The following is a description of a gene set: Genes up-regulated in day 40 memory B cells versus day 40 germinal center B cells. Human Gene Set: GSE11961_MEMORY_BCELL_DAY40_VS_GERMINAL_CENTER_BCELL_DAY40_UP species: Homo sapiens To obtain insight into the genetic basis of the increase of functional activity of memory B cells over time, we compared the gene expression profiles of day 7 and day 40 NP-specific/IgG1 memory B cells, GC B cells and plasma cells in immunized WT mice and naïve B cells, before and after activation in vitro. from publication Kaji T, Ishige A, Hikida M, Taka J, Hijikata A, Kubo M, Nagashima T, Takahashi Y, Kurosaki T, Okada M, Ohara O, Rajewsky K, Takemori T (PMID 23027924), and this is the list of marker genes: TUT7, HAUS5, PLXNC1, FIBP (FGF1 intracellular binding protein), ARMC6, ROBO2 (NCBI Gene Id 90370), MFSD2B, VPS33B, AMMECR1, AQP9, RGS9, XPO5, FYCO1, WDFY2, LZTS2, HINT3 (histidine triad nucleotide binding protein 3), CHEK2, TBX3 (T-box transcription factor 3, NCBI Gene Id 91834), SEC14L2, ZKSCAN4, STARD3, ABCC3, CNIH4, ZNF420, VPS54, TMEM43, RAI2, NPB, FBXO4, GRIK1, CNTN3, COG4, PES1, IPO4, DTNB, APOOL, POGK, PDZK1IP1, TDRD12, TRAPPC12, SERAC1, KLC3, TRAPPC14, LSM10, GPSM2, GABRG1, PTPN12, KCNC2, TPCN2, MPDZ, EPHA5, ADH4, NAP1L3, ANKRD29, ZNF354A, C2CD2, ARHGEF39 (NCBI Gene Id 84904), FIGN, FAT3, RHOT2, PLSCR3, TBC1D32, DPY30, AP5Z1, ICAM2, ZBTB42, ZNF438, RNF40, WDR25, ARHGAP45, SOCS4, CNTNAP2, TBRG4, SLIT2, PPIL6, LAD1, OSBPL5, HSPA8, NOVA1, ANK2, DZANK1, USP21, PLEKHO2, MROH1, EFNA5, SMTN, LASP1, ANO10, RGS8, CFAP300, FARSA, DNAJA1, KNSTRN, ARHGAP5, PKP3, DUS3L, PYGB, FAM216A, IGDCC4, PLOD2, MYBPC1, TTC3, DEGS1, NGLY1, CDH1, TNKS1BP1, SRR, ZFPM1, ASS1, NOC4L, TSGA13, CXCL13, SERPINC1, EDN3, LTBP1, FAM89A, SLC39A12, ZSCAN29, PSRC1, OSBPL3, MECOM, SNRNP35, SPATS1, CCNA2, PLEKHH1 (NCBI Gene Id 57475), GNB2 (G protein subunit beta 2), TSGA10, GGCX, C1orf159, LZTR1, PLCB3, C1R, CCP110, POLR1B, CRADD, COX7B2, COL20A1, TPBG, BCAS1, KAT2A, EIF4ENIF1 (NCBI Gene Id 56478), GBP4, EFEMP1, NDRG1, TNS1, PIEZO1, NEDD4L (NCBI Gene Id 93998), CDH8, TIPRL, ANKS1A, CCDC77, TRIM17 (tripartite motif containing 17), CCHCR1, SCLY, RAD17, JAK3, TM6SF2, SAMD1, ABHD12, KHNYN, TMEM81, KCNH5, ADHFE1, KCNA3, HOXC8, HAUS8, STOX2, HS6ST2, CYP2C18, TASOR2, DNAJC1, CADM2, KCNJ3, CAPN2, BUB1B, ZIC1, HAO2, GMPS, SLCO4C1, SPMIP4, KCNJ8, FOCAD, TMEM181, NME6, GPM6A, IL13RA2, NKAPL, NUP50, PSMC3IP, ZNF622, PLCXD3, DPP9, FXR1, APEX2, TGFBI, UNC13D, GPR19 (NCBI Gene Id 2842), JPH1